Given this list of marker genes FNBP1, ATP6V0B, BAGE2, GSTM4, CHST2, ZZZ3, KLHDC10, SYN3, NR3C1, SNX1, ZFP1, MTCL2 (microtubule crosslinking factor 2), B4GALT2, XRN1, KLHDC7A, DSTYK, THSD7A, CD1C, TENT4A, EYA3, ZC3H4, CCK, ATP1B1, SERINC1, ZNF341, DTX3L, ADAM10, ZNF704, ZNF69, ADARB2, VPS26B, FAM20A, SLC52A3, CUX2, DNAJC18, FRMPD4, ST6GAL2, GPX7, LILRB4, SLC15A1, ORAI2, PRDM16, C5orf24, BNIP3L, TK2, PTPRO, SEMA5B, CAMLG, TMEM104, CHD6, PCDHA2, PPFIA2, MAPK14, MRTFB, ARIH1, SLC16A9, NFIB, ARNT2, RAP2B, SOWAHB, TEF, FKTN, TIMM17A, TSN, DDX6, ANKRD16 (NCBI Gene Id 54522), SRGAP3, FSD2, PROX1, NR4A3, KSR2 (NCBI Gene Id 341537), KIAA1549L, NAV3, TTC23, NPAS3, ESF1, RPGR, P2RY13, MYRIP, ABHD11 (abhydrolase domain containing 11), ZNF786, PRKCB, here is a description of the gene set: Human Gene Set: MIR6791_3P Genes predicted to be targets of miRBase v22 microRNA hsa-miR-6791-3p in miRDB v6.0 with MirTarget v4 prediction scores > 80 (high confidence targets). species: Homo sapiens from publication Chen Y, Wang X (PMID 31504780)